The following is a description of a gene set: Collagen formation studied in species Homo sapiens Human Gene Set: REACTOME_COLLAGEN_FORMATION, and this is the list of marker genes: COL25A1 (NCBI Gene Id 84570), TLL2, COL7A1, COL9A2, LAMA3, COL5A1, COL8A1 (NCBI Gene Id 57086), LOXL4, COL6A5, COL17A1, COL4A3, MMP3, ADAMTS14, DST, P3H2, COLGALT1, COL23A1, MMP9, COL22A1, ITGA6, COL14A1, COL6A1, LAMC2, COL4A1, LAMB3, LOXL2, P3H3, LOX, PCOLCE2, PPIB, PXDN (peroxidasin), SERPINH1, COL27A1, ADAMTS2, P4HB, COL20A1, COL4A5, CD151, COL9A3, LOXL3, MMP13, MMP7, COL15A1 (NCBI Gene Id 1306), PCOLCE, COL5A2, COL8A2, LOXL1 (NCBI Gene Id 4016), ITGB4 (integrin subunit beta 4), COL5A3, COL16A1, COL10A1, COL4A2, COL6A2, TLL1, PLOD2, P4HA1, BMP1, COL11A2, COL3A1, COL12A1, COLGALT2, CRTAP, COL4A4, COL11A1, COL4A6, COL26A1, CTSS, MMP20, COL24A1, COL1A1 (NCBI Gene Id 4970), P4HA2, COL13A1, COL18A1, CTSB, COL2A1, COL19A1, ADAMTS3, CTSV, P4HA3, CTSL, PLOD3, COL21A1, COL28A1, COL6A3, PLOD1, COL9A1, COL6A6, PLEC (plectin), P3H1, COL1A2